The following is a description of a gene set: Human Gene Set: MIR4720_5P species: Homo sapiens Genes predicted to be targets of miRBase v22 microRNA hsa-miR-4720-5p in miRDB v6.0 with MirTarget v4 prediction scores > 80 (high confidence targets). from publication Chen Y, Wang X (PMID 31504780), and this is the list of marker genes: STARD13, WASL (WASP like actin nucleation promoting factor), EBAG9, GCNT2, CREBRF, STIMATE-MUSTN1, BCORL1, FAM171A1, LRIG3, HYCC2, SLC38A2 (NCBI Gene Id 95454, solute carrier family 38 member 2), ARHGEF38, N4BP2L1, ALPK3, SND1, ERICH3, ZNF512B, AFDN, PDE6A, JMJD1C, ACKR3, TAFA3, DPY19L2, VANGL1, KRT32, BTBD7, NF1, XAGE1B, ANP32E, LSM8, MAP2, SV2C, PLXDC2 (plexin domain containing 2), CDC26, SLC25A4, LEPROTL1, PIK3R1, DKK2, BNIP1, PPP1R9B, ABRAXAS2, PPFIBP1, BTBD1, MUSTN1, MRGBP, ARMC1, EGLN1, MYBL1, UBE2G1, OSTF1, CHST15, ISX, SC5D, REST, FBXO33, STOX2, PHACTR2, DNAJC24 (NCBI Gene Id 120526), NBEA, RIOK3, PLPPR1, KRT74, SHOC2, SDK2, AGAP1, NKAIN2, GAN, GTF2E1, L3HYPDH (NCBI Gene Id 112849), USP16, ZDHHC2, WRNIP1, DLEU7, BACH2, TNP1, SF3B1, MGAM, CDX2, GPAT3, YY1, TLR2, GTSF1, BRWD3, RER1, COL13A1, RAB3C, PLXNA2, COBLL1, FOXJ3